The following is a description of a gene set: Human Gene Set: DESCARTES_FETAL_PLACENTA_IGFBP1_DKK1_POSITIVE_CELLS from publication Cao J, O'Day DR, Pliner HA, Kingsley PD, Deng M, Daza RM, Zager MA, Aldinger KA, Blecher-Gonen R, Zhang F, Spielmann M, Palis J, Doherty D, Steemers FJ, Glass IA, Trapnell C, Shendure J (PMID 33184181) Marker genes curated from the annotated cluster as represented in the Descartes Human Gene Expression During Development database. The gene expression program underlying the specification of human cell types is of fundamental interest. The study authors generated human cell atlases of gene expression and chromatin accessibility in fetal tissues. For gene expression, the study authors applied three-level combinatorial indexing to >110 samples representing 15 organs, ultimately profiling ~4 million single cells. The study authors leveraged the literature and other atlases to identify and annotate hundreds of cell types and subtypes, both within and across tissues. Our analyses focused on organ-specific specializations of broadly distributed cell types (such as blood, endothelial, and epithelial), sites of fetal erythropoiesis (which notably included the adrenal gland), and integration with mouse developmental atlases (such as conserved specification of blood cells). These data represent a rich resource for the exploration of in vivo human gene expression in diverse tissues and cell types. studied in species Homo sapiens, and this is the list of marker genes: IGFBP2, ADAMTS4, GAS1, PEMT, C1R, CACNB2, SCARA5 (scavenger receptor class A member 5), MXRA8, ROS1, GLB1L2, DIRAS2, CAB39L, FAM131B-AS2, RGS17, DPYD-AS1, LINC01435, ISLR, BRINP2 (NCBI Gene Id 57795), CHRD, ADRA2C, FOXL2, ADAMTS8, STAC2, IGFBP4, COX7A1, SPOCK1, RORB, MEDAG, CD82, CNR1, THY1, GPR176 (NCBI Gene Id 11245), LGALS1, COL4A4, RBP1, NR1D1, LRRC15, OSR2, POLR1F, OMD, WT1, SULF2, CRLF1, ALDH1A3 (aldehyde dehydrogenase 1 family member A3), WNT5A, HTR2B, TMEM45A (NCBI Gene Id 55076), CTSK, OSGIN2, RGS2, IGFBP1, SSC5D, CHI3L2, PCSK1, IGSF10, WNT4, PRL, GALNT13, LEFTY2, IGFBP5, PARM1, S100A3, CHRDL1, NPR3, WT1-AS, TIMP1 (TIMP metallopeptidase inhibitor 1), NTRK1, CFD, ADGRG2, PGR, HSD11B1, LUM, MOV10L1, PHYHIP, CPXM1, CILP, PLAC9P1, AOX1, P4HA3, TNFRSF8, PLPP1, SHISAL1, MAP3K4-AS1, CYP1B1, NDP, RAMP1, MFGE8, SDC3, PROK1, PRR15, ING1, IGFBP6, TRPC4, KCND2, MELTF, HSPB6, LETR1, GRIA3, IL1A, ENTPD3, GGT5, IL1RL1, LRRN4CL, DKK1, TEX26-AS1, C11orf96, HOXD10, MEGF10, RORB-AS1, HEPH (NCBI Gene Id 9977), CD248, MAOB, DPP6, PCDH20, APOD, TMEM132C, WDR86-AS1